The following is a description of a gene set: An abnormally decreased concentration of parathyroid hormone. Human Gene Set: HP_DECREASED_CIRCULATING_PARATHYROID_HORMONE_LEVEL studied in species Homo sapiens Decreased circulating parathyroid hormone level, and this is the list of marker genes: TBX1, CASR, SLC34A3, AIRE, SLC34A1, GCM2, TBCE, PTH, CYP24A1, SAMD9